Given this list of marker genes SYS1, TMIGD3, IVD, KCNJ2, PPP1R12B, RAB11FIP5, RCOR1, CTDSP2, PEX10, WAC, ZNF385C, CCDC121, PLPPR5, ACTA2, ZNF860, NUP210, OTUD4, MYCN, SLC22A8, SIMC1, GSTA1, SIK3, CIDEB, SHPRH, PAK5, CHST9, CBLB, ZBTB20, CNOT9 (CCR4-NOT transcription complex subunit 9), here is a description of the gene set: studied in species Homo sapiens from publication Chen Y, Wang X (PMID 31504780) Genes predicted to be targets of miRBase v22 microRNA hsa-miR-6069 in miRDB v6.0 with MirTarget v4 prediction scores > 80 (high confidence targets). Human Gene Set: MIR6069